The following is a description of a gene set: A crucial step in human breast cancer progression is the acquisition of invasiveness. There is a distinct lack of human cell culture models to study the transition from preinvasive to invasive phenotype as it may occur spontaneously in vivo. To delineate molecular alterations important for this transition, we isolated human breast epithelial cell lines that showed partial loss of tissue polarity in three-dimensional reconstituted basement membrane cultures. These cells remained noninvasive; however, unlike their nonmalignant counterparts, they exhibited a high propensity to acquire invasiveness through basement membrane in culture. The genomic aberrations and gene expression profiles of the cells in this model showed a high degree of similarity to primary breast tumor profiles. The xenograft tumors formed by the cell lines in three different microenvironments in nude mice displayed metaplastic phenotypes, including squamous and basal characteristics, with invasive cells exhibiting features of higher-grade tumors. To find functionally significant changes in transition from preinvasive to invasive phenotype, we performed attribute profile clustering analysis on the list of genes differentially expressed between preinvasive and invasive cells. We found integral membrane proteins, transcription factors, kinases, transport molecules, and chemokines to be highly represented. In addition, expression of matrix metalloproteinases MMP9, MMP13, MMP15, and MMP17 was up-regulated in the invasive cells. Using small interfering RNA-based approaches, we found these MMPs to be required for the invasive phenotype. This model provides a new tool for dissection of mechanisms by which preinvasive breast cells could acquire invasiveness in a metaplastic context. studied in species Homo sapiens Genes up-regulated in monolayer (2D) cultures of preinvasive (S3-C) vs invasive (T4-2) breast cancer cells. from publication Rizki A, Weaver VM, Lee SY, Rozenberg GI, Chin K, Myers CA, Bascom JL, Mott JD, Semeiks JR, Grate LR, Mian IS, Borowsky AD, Jensen RA, Idowu MO, Chen F, Chen DJ, Petersen OW, Gray JW, Bissell MJ (PMID 18316601) Human Gene Set: RIZKI_TUMOR_INVASIVENESS_2D_UP, and this is the list of marker genes: SPHK2 (NCBI Gene Id 56848), NFATC3, NQO2, MYCL, SLC10A2, HMGCL (3-hydroxy-3-methylglutaryl-CoA lyase), TAF12 (NCBI Gene Id 6883), PDYN, SLC39A6, ABCD4, TAOK2, NAB2, TMEFF1, AMD1, LSM7, SLC35B1, COL4A6, KLF2, DPM2, C3AR1, LSS, DNAJC27, SRRM1, CYP27B1, DUSP2, COPB2, TAF10, STAT5A, TYRP1, GPKOW, TGFBR3, PLPP3, BTG3, NCL, DCTN1, RNF4, H3-3B, SPTAN1 (spectrin alpha, non-erythrocytic 1), MLLT6 (NCBI Gene Id 4302), UBA1, ACTL6A, NBN, IDI1, KCNE5, GUCY1A1, HPGDS, CAD, DPP3, ADAR, MYL3, SMARCE1 (NCBI Gene Id 6605), GPR19, ECI2, ACOT8, CD24, TG, REV3L, SERPINA4, LRP3, STK10, STARD3, ACVR1, GNA11, IGF2, CSF3R, TUBGCP3, EIF4A2, PAEP, INSL4